The following is a description of a gene set: The chemical reactions and pathways resulting in the breakdown of a protein or peptide by hydrolysis of its peptide bonds, initiated by the covalent attachment of ubiquitin, with ubiquitin-protein ligation catalyzed by the anaphase-promoting complex, and mediated by the proteasome. Human Gene Set: GOBP_ANAPHASE_PROMOTING_COMPLEX_DEPENDENT_CATABOLIC_PROCESS species: Homo sapiens, and this is the list of marker genes: FBXO31, ANAPC16, ANAPC4, ANAPC7, ANAPC13, ECRG4 (ECRG4 augurin precursor), ANAPC1, ANAPC5, CDC20B (NCBI Gene Id 166979), ANAPC10, CDK2 (cyclin dependent kinase 2), ANAPC2, ANAPC11, CDC23, UBE2C, ANAPC15, CDC27, UBE2S, CDC26, CDC16, FZR1, CDC20, CUL3, PLK1